The following is a description of a gene set: part of: Signaling by WNT Reactome Pathway: Beta-catenin independent WNT signaling Humans and mice have 19 identified WNT proteins that were originally classified as either 'canonical' or 'non-canonical' depending upon whether they were able to transform the mouse mammary epithelial cell line C57MG and to induce secondary axis formation in Xenopus. So-called canonical WNTs, including Wnt1, 3, 3a and 7, initiate signaling pathways that destabilize the destruction complex and allow beta-catenin to accumulate and translocate to the nucleus where it promotes transcription. Non-canonical WNTs, including Wnt 2, 4, 5a, 5b, 6, 7b, and Wnt11 activate beta-catenin-independent responses that regulate many aspects of morphogenesis and development, often by impinging on the cytoskeleton. Two of the main beta-catenin-independent pathways are the Planar Cell Polarity (PCP) pathway, which controls the establishment of polarity in the plane of a field of cells, and the WNT/Ca2+ pathway, which promotes the release of intracellular calcium and regulates numerous downstream effectors. studied in species Homo sapiens, and this is the list of marker genes: PRKG1, GNB5, PSMC2, PSMB5, PFN1, CLTC, GNB4, CLTA, CLTB, SMURF2, GNGT2, ITPR2, PRKCB, GNAT2, UBB, PSMC3 (NCBI Gene Id 96121), PSMC6, WNT5A, RHOA, PSMB2, FZD2, WNT5B, GNB1, PSMD14, PLCB2, UBA52, CALM1, WNT1, MOV10, PSMA3, FZD6, AP2B1, PRKG2, RAC2, PSMA6 (proteasome 20S subunit alpha 6), GNG13, ARRB2, PSMA5, CAMK2A (calcium/calmodulin dependent protein kinase II alpha), PSMD12, PLCB3, KRAS, PSMA1, PRKCG, AGO1, ROR2, ROR1, PSMD6, SMURF1, PPP3CB, PSMD3, TNRC6B, WNT4, PSMC5, PARD6A, PSMD8, VANGL2, PSMC4, GNG8, AGO2, RPS27A, GNB2, PSMD11, RAC1, DAAM1, MYC, GNG7, PSMD2, LEF1, ADRM1, GNG5, RAC3, PLCB1, CTNNB1, FZD3, PSMD1, ITPR3, SEM1, RYK, TCF7L1, UBC, PPP3R1, AP2A2 (NCBI Gene Id 25955), DVL2, NLK, AGO4, PSMB4, AP2S1, GNAO1, AP2M1, FZD4, PDE6G, PSMC1 (NCBI Gene Id 5700), DVL3, GNG12, FZD1, FZD7, PSMA7, SCRIB, PSMA2, AXIN2, PSMB3, GNGT1, AGO3, GNG11, PRICKLE1, GNB3, GNG2, PSMB7, TNRC6C, TNRC6A, PSMB1, PDE6B, MIR92b, PDE6A, PSMD7 (proteasome 26S subunit, non-ATPase 7), AP2A1, PSMD13, WNT11, GNG10, DVL1, ITPR1, GNG3, MAP3K7, PRKCA (NCBI Gene Id 5578), PPP3CA, TCF7, NFATC1, PSMA4, TCF7L2, FZD8, GNG4, FZD5, PSMB6